Given this list of marker genes USP3, RBFOX2, CSNK1E, NKTR, BDH1, GATC, ANKRD28, MYF5, FZD4 (frizzled class receptor 4), SPA17, MN1, ZNHIT1, UBXN8, CYREN (NCBI Gene Id 78996), LRRC37A2, DGCR11, CCDC85B, SDC4, ADGRG1, PDLIM2, CHIT1, MEIS1, LRRFIP1, TIAM2, HAPSTR1, ZSCAN26, RTCA, TNIP1, IQCB1, TRPV5, CALM1, GABRP, THYN1, SLC30A1, ANKRD11, SNUPN, POLD2, ZNF230, MARS1, TM4SF1, MMP19, SHROOM2, DPM3, WASF3, EPX, LMCD1, VIPAS39, PLD1, PGAM1, EPHB4, RPS6KA2, SLC6A4, IFRD1, POLB, TSPAN5, CERK, ST3GAL6, MUC2, MIOS, BCAS4, TLE1, TAAR2, CTNNAL1, ZMIZ1, TPSD1, SLC1A4, MPP1, PCK2, ABTB2, IMPA2, NDUFS7, AGT, ZNF419, CLCN4, PMPCB, NDUFA8, MID1IP1, DDIT4, H1-0, TJP2, BRCC3, KYNU, ITGA2, TAX1BP1, BNIP3L, MAGEF1, ACVR2A, CDYL, CDC42EP3, DGCR6L, METTL5, SUCLG1, CENPS, LYL1, METTL18, PRDM11, PRODH2, SLC35F2, ARB2A, CYP26B1, HOMER3, RBM38, DEFB4A (NCBI Gene Id 1673), RRH, RNF41, LIAS (NCBI Gene Id 94182), CD5, HILPDA, WDR73, TM6SF1, RAPGEF5, NDOR1, ZNF232, GABRB2, DDX28, ESM1 (NCBI Gene Id 11082), POLG2, ZNF444, RPP40, SIK3, TRMT12, NPVF, FGL1, PNMA2, PLPPR3, VEGFA, ITPKB, LINC00939, SMUG1, FMNL1, NACA2, KIT, UTP25, ORAI3, TSC22D3, FMOD, LHX5, PARK7, PIGC, ASCC1, ATP8B3, MRPS14, NUDT6, SYNGR4, AKR7A2, MNDA, NME5, WASHC3, CNPY4, NPM3, TACSTD2, POLR2F, NOLC1, SPRY2, ACTR3B, MEPCE, FOLR2, ABR, IFT88, GDPD5, PPCDC, CCN4, SLC25A36, FJX1, HOXA6, LXN, AHSG, ARRB1, FYN, HBEGF, NOL3, ATP5PB, MICAL2, TMEM186, DHRS7, SHB, NT5C2, PECAM1 (platelet and endothelial cell adhesion molecule 1), SLC7A1, STAU2, RUFY3, WWOX, EHD4, TRMT2A, NME7, SOCS2, ERBB3, IER3, RAMP2 (NCBI Gene Id 10266), ZNF23, CHRNG, CERT1, MORC2, TRIM8, DZANK1, SLC2A1, here is a description of the gene set: from publication Cipolletta D, Feuerer M, Li A, Kamei N, Lee J, Shoelson SE, Benoist C, Mathis D (PMID 22722857) Human Gene Set: GSE37533_PPARG1_FOXP3_VS_PPARG2_FOXP3_TRANSDUCED_CD4_TCELL_PIOGLITAZONE_TREATED_UP We identified Pparg as a major orchestrator of the phenotype of adipose-tissue resident regulatory T cells (VAT Tregs). To explore the contribution of Pparg1 and 2 in the generation of the VAT Tregs-specific gene signatures, CD4+FoxP3- T cells were transduced with Foxp3+/- Pparg1 (or Pparg2), treated with Pioglitazone or vehicle, and double sorted for microarray analysis. Genes up-regulated in CD4 T cells treated with pioglitazone and over-expressing: FOXP3 and PPARg1 isoform of PPARG versus FOXP3 and PPARg2 form of PPARG. studied in species Homo sapiens